Given this list of marker genes Rb1, Bahd1, Ezh2, Eed, L3mbtl1, Suz12, Rrp8, Sirt1, Suv39h1 (NCBI Gene Id 20937), Cbx3, Baz2a, Smarca5, Yy1, here is a description of the gene set: Any protein complex that mediates changes in chromatin structure that result in transcriptional silencing. species: Mus musculus Mouse Gene Set: GOCC_CHROMATIN_SILENCING_COMPLEX